Given this list of marker genes Sfn, Gadd45a, Pcna, Aurka, Cdk1, Ccnb1, Bax (NCBI Gene Id 12028), here is a description of the gene set: TP53 Regulates Transcription of Genes Involved in G2 Cell Cycle Arrest studied in species Mus musculus Mouse Gene Set: REACTOME_TP53_REGULATES_TRANSCRIPTION_OF_GENES_INVOLVED_IN_G2_CELL_CYCLE_ARREST